The following is a description of a gene set: Mouse Gene Set: GOCC_NUCLEAR_PERIPHERY The portion of the nuclear lumen proximal to the inner nuclear membrane. studied in species Mus musculus, and this is the list of marker genes: Lmnb2, Nup153, Narf, Anapc4, Eif6, Dag1, Lmna, Nup107, Sp100 (NCBI Gene Id 20684), Atf4, Lmnb1, Pias1, Nup205 (nucleoporin 205), Cask, Prr14, Lmntd2, Nup93, Mapt, Tpr, Nrm (nurim (nuclear envelope membrane protein)), Nup35, Ifi211, Msx1, Ebna1bp2, Rnf220, Map2 (NCBI Gene Id 17756), Hlcs, Stx1b, Nup98, Emd, Lbr, Suv39h1, Psip1, Pcna